The following is a description of a gene set: species: Homo sapiens Human Gene Set: GOBP_REACTIVE_NITROGEN_SPECIES_METABOLIC_PROCESS The chemical reactions and pathways involving a reactive nitrogen species., and this is the list of marker genes: MTARC2, TMEM106A (transmembrane protein 106A), MIR181B1, SIRPA, ACP5, ASL, DDAH2, APOE, AKT1, PRDX5, CPS1 (carbamoyl-phosphate synthase 1), SLC7A6, CAV1, TSPO, KLRK1, NOS3, MIR181A2, OPRM1, IL10, PTX3 (pentraxin 3), SELENOS, CX3CR1, CYGB, KLF4, MIR92A1, ZDHHC21, NFATC3, GLA, NQO1, HSP90AB1 (NCBI Gene Id 3326), INSR, TLR5, GCH1 (NCBI Gene Id 93984), CYB5R3, CLU, IL1B, GCHFR, CYP1B1, STAT1, ACVR2A, JAK2, NPY, TNF, CYP1A1, KLRC4-KLRK1, P2RX4, PIK3CB, DYNLL1, ATP2B4, CD36, KLF2, ROCK2, RORA, RAC1, ITGB2, SOD2, PTGIS, SMAD3, NOS1AP, DDAH1, PPARA, TLR6, TICAM1 (TIR domain containing adaptor molecule 1), ZC3H12A, NOSIP, SPR, APP, EDN1, CD47, HBB, CLEC7A, PTGS2, THAP4, AGXT2, IFNG, MIR199A1, MIR99B, KHSRP, PKD2, ESR1, MTARC1, HIF1A, NOS2, IGF1, NOS1, TLR4, CYB5B, ARG2, POR, HSP90AA1, ASS1